The following is a description of a gene set: studied in species Mus musculus Mouse Gene Set: LEE_AGING_MUSCLE_UP Upregulated in the gastrocnemius muscle of aged adult mice (30-month) vs young adult (5-month) from publication Lee CK, Klopp RG, Weindruch R, Prolla TA (PMID 10464095) The gene expression profile of the aging process was analyzed in skeletal muscle of mice. Use of high-density oligonucleotide arrays representing genes revealed that aging resulted in a differential gene expression pattern indicative of a marked stress response and lower expression of metabolic and biosynthetic genes. Most alterations were either completely or partially prevented by caloric restriction, the only intervention known to retard aging in mammals. Transcriptional patterns of calorie-restricted animals suggest that caloric restriction retards the aging process by causing a metabolic shift toward increased protein turnover and decreased macromolecular damage., and this is the list of marker genes: Fos, Hint1, Gadd45a, Arf5, Arhgdib, Ap3s2, Hspa8, Dctn1, Ckmt2, Hba-a1, Plagl1, Tgfb1i1, Mfap5, Gdf9, Rab21, Ntf3, Cdc42, Rhob (NCBI Gene Id 11852), Tspan8, Saa-ps, Bub3, Zfp90, Nampt, Sox17, U2af2, Hspb1, Pou3f2, Aldh1a1, Rab1a, Smarcc2, Tfap2b, Krtap5-4 (NCBI Gene Id 50775), Atf3, Amy1, Actr1b, Stard7, Tgif1, Ddx5, Htra1 (HtrA serine peptidase 1)